Given this list of marker genes RELN, SLIT2, FBXO45, LHX6, ROBO1, ARX, here is a description of the gene set: species: Homo sapiens The migration of cells in the cerebral cortex in which cells move orthogonally to the direction of radial migration and do not use radial glial cell processes as substrates for migration. Human Gene Set: GOBP_CEREBRAL_CORTEX_TANGENTIAL_MIGRATION